Given this list of marker genes Pin1rt1, Pten, Cdc20b, Cdkn1b, Entrep1 (endosomal transmembrane epsin interactor 1), Pex12, Cdc20, Btrc, Rbck1, Fzr1, Pin1, here is a description of the gene set: Binds to and increases the activity of a ubiquitin ligase. species: Mus musculus Mouse Gene Set: GOMF_UBIQUITIN_LIGASE_ACTIVATOR_ACTIVITY